The following is a description of a gene set: Abnormal cortical gyration An abnormality of the gyri (i.e., the ridges) of the cerebral cortex of the brain. Human Gene Set: HP_ABNORMAL_CORTICAL_GYRATION species: Homo sapiens, and this is the list of marker genes: TRIM8, ZNF335, ACTG1, FDFT1, MECP2, TUFM, ATP6V1B2, DCHS1, TMEM218, ATP6V1E1, PEX13 (peroxisomal biogenesis factor 13), PIGB, RELN, B9D1, COL25A1, ACTA2, SCN2A, KLHL15, NSDHL, TBR1, GLI2, LAGE3, CASP2, CCND2, IFT74, KIF2A, PEX1 (peroxisomal biogenesis factor 1), CEP41, CTU2, RAB18, DPF2, GON7, YWHAE, NAA60, IER3IP1, RAC1, DOCK6, USP18, OSGEP, WWOX (NCBI Gene Id 9621), FBXL4, TMX2, GPHN, ISCA1 (NCBI Gene Id 92236), VPS4A, NUP37, ARL3, MTOR, XRCC4, POMT1, LARGE1, HIC1, HSD17B4, LIPT2, TRMT10C, KIF21A, TMTC3 (transmembrane O-mannosyltransferase targeting cadherins 3), KIF26A, SIK1, KIAA0753, LRPPRC, ANKLE2, PHGDH, SNRPN, ARID2, TOGARAM1, FGF8, DCX, CSPP1, CRPPA, PRKDC, PEX2, ETFB (electron transfer flavoprotein subunit beta), TBC1D20, TSEN15, TMEM67, RNU12, PIGQ, ROBO1, RAB3GAP1, INPP5E, PLK4, ARID1A, PI4KA, ATP1A3, MAPK8IP3, SRD5A3, HYLS1, TCTN1, COPB2, CILK1, CDK5, GMNN, MAN2C1, SMARCE1, TRAPPC14, LAMC3, NDN, CSNK2A1, GMPPB, TTC5, METTL5, NPHP1, CCBE1, PIBF1, POU4F1, VRK1, ETFA, DYNC1I2, STAMBP, CEP152, NEUROD2, DISP1, PTEN, TMEM222, INTS11, PEX19 (NCBI Gene Id 7835), B3GALNT2, ARHGEF9, APC2, TGIF1, MPDZ, PEX14, CEP120, DHX37, RPGRIP1L, NDUFA6, FLI1, KATNIP, PAX6, AHI1, ZNF526, PNKP, TSEN54, SNF8, DLK1, CPLANE1, SRPX2, KIFBP, MCPH1, TSEN2, MAST1, CIT, SARS1, GRIN1, MED27, OFD1, VAC14, EML1, C2CD3, SOX4, STIL, CEP85L, NDE1, SON, ETFDH (NCBI Gene Id 2110), ACTB, PEX16, CEP104 (NCBI Gene Id 9731), DHCR24 (24-dehydrocholesterol reductase), BICD2, ASPM, AKT3, VPS33B, SMPD4, MLYCD, ATXN2, GAS1, BLTP1, EXOSC5, DYNC1H1, POMGNT2 (NCBI Gene Id 84892), CDK5RAP2, CAMSAP1, ASNS, GNAO1, POMK (protein O-mannose kinase), CPT2, ATP6V1A, NFIX, TUBB3, MFSD2A, KIF14, FRAS1, ZNHIT3, PDHB, CASK, TBC1D24, PIGP, LMNB2, TUBB2B, TRAPPC10, TUBA1A, COL18A1, LMNB1, LONP1 (NCBI Gene Id 9361), TP73, COL4A1, PIK3CA, GRM7, SLC5A6, MCM7, PLAA, SHMT2, FBXO28, PDCD6IP, TUBGCP6, LAMB1, RNU4-2 (RNA, U4 small nuclear 2), WARS1 (NCBI Gene Id 7453), PEX11B, CLP1, CCDC88A, WDR62, PEX3, ATP1A2, PPIL1 (NCBI Gene Id 5482), EIF2AK2, SLC30A9 (solute carrier family 30 member 9), RTL1, SEPSECS, POMGNT1, GPSM2, RRAGC, DLL1, FOXH1, TMEM237, AHDC1, GNB1, KCNA1, RECQL4, SIN3A, WDR26, ESAM, SHH, YRDC, TUBB2A, SMARCD1, NEDD4L, NANS, TAF13, ARMC9, GPX4, TP53RK, KIF5C, CUL4B, SMARCC2, MAP1B, WDR73 (WD repeat domain 73), TUBG1, CEP295, CEP135, GFM2, ADGRG1, VLDLR, OCLN, CBY1, EXOC7, PPP1R12A, SNAP29, SASS6, AXIN1, CDON, FH, POGZ, PIDD1, SOX11, WBP4, SCN3A, WT1, CENPE, CEP63, PIK3R2, PEX26, MBOAT7, FAT4, NODAL, FRMD5, FOXG1 (NCBI Gene Id 2293), CAMTA1, NARS1, DONSON, PEX10, COG6, TRAPPC12, ARID1B, ERCC1, POLR3A, IBA57, NPRL3, FTO, MICU1, ALG12, ARL13B, MAGEL2, CDKL5, FLVCR2, WDR4, OCA2, TPRKB, ADAMTS3, PSAT1, KIF11, FKRP, PDHA1, SIX3, NSRP1, PDE6D, ODC1, COL4A2, MYCN, FIG4, SMO (smoothened, frizzled class receptor), PAFAH1B1, STS, KAT5, NUP133, SPOP, USP9X, ATN1, TUBA8, SMARCB1, VIPAS39, RNU4ATAC, SLC32A1, PEX12, ZIC2, TUBB, EOMES, MEG3, PEX6, TCTN2, KATNB1, SMARCA4, SUFU, FKTN, DMXL2, CDK6, QARS1, PEX5, CRADD, KIAA0586, KAT6B, ATR, SLC25A22, TSEN34, SLC25A19, SCN1B, ATP6V0A2, NCAPD3, POMT2, ASCC1, NUP107, BMPER, SF3B4, TUBGCP2, PYCR2, KNL1, RTTN, TRRAP, SUZ12, MACF1, TRAIP, B4GAT1, ZEB2, CDC40, TBL1XR1, GLS, RXYLT1, NPRL2, ARHGAP31, PLP1, RAB3GAP2, ARX, DAG1, MN1, DEPDC5, PHOX2A, CRIPTO, PPFIBP1, RMND1, NEK1, PTCH1, MKS1, PHC1, LAMA2, MED11, CTNNA2, ERMARD, COL3A1, TCTN3, B9D2